The following is a description of a gene set: Up-regulated genes in the subpopulation of invasive PyMT cells (breast cancer) compared to the general population of PyMT cells. from publication Wang W, Wyckoff JB, Goswami S, Wang Y, Sidani M, Segall JE, Condeelis JS (PMID 17440055) Correlating tumor cell behavior in vivo with patterns of gene expression has led to new insights into the microenvironment of tumor cells in the primary tumor. Until now, these studies have been done with cell line-derived tumors. In the current study, we have analyzed, in polyoma middle T oncogene (PyMT)-derived mammary tumors, tumor cell behavior and gene expression patterns of the invasive subpopulation of tumor cells by multiphoton-based intravital imaging and microarray-based expression profiling, respectively. Our results indicate that the patterns of cell behavior that contribute to invasion and metastasis in the PyMT tumor are similar to those seen previously in rat MTLn3 cell line-derived mammary tumors. The invasive tumor cells collected from PyMT mouse mammary tumors, like their counterparts from rat xenograft mammary tumors, are a population that is relatively nondividing and nonapoptotic but chemotherapy resistant and chemotactic. Changes in the expression of genes that occur uniquely in the invasive subpopulation of tumor cells in the PyMT mammary tumors that fall on the Arp2/3 complex, capping protein and cofilin pathways show a pattern like that seen previously in invasive tumor cells from the MTLn3 cell line-derived tumors. These changes predict an enhanced activity of the cofilin pathway, and this was confirmed in isolated invasive PyMT tumor cells. We conclude that changes in gene expression and their related changes in cell behavior, which were identified in the invasive tumor cells of cell line-derived tumors, are conserved in the invasive tumor cells of PyMT-derived mouse mammary tumors, although these tumor types have different genetic origins. Mouse Gene Set: WANG_TUMOR_INVASIVENESS_UP studied in species Mus musculus, and this is the list of marker genes: Plod1, Brd4, Nelfe, Kifap3, Cd63, Ifitm1 (NCBI Gene Id 68713, interferon induced transmembrane protein 1), Aph1a, Wdr75 (NCBI Gene Id 96871), Ezr, Tjp2 (tight junction protein 2), Ppan, Mtmr3, Pou2f3, Psma2, Acat2, Sgpl1, Tex10, Fau, Pmpca, Sap18, Prkar1a, Stk11, Ezh2, Vdac3, Trim28, Nap1l1, Npc2, Rbm10, Cdca3, Per1, Psmb4, Ndufc2, Nucks1, Abcf1, Dpp3, Ndufs4, Klhl17, Ergic3, Hnrnpa2b1, Ap3m1, Syk, Ak2, Plac8, Ndufs6, Eif4g2, Tubb2b, Rps14, Cend1, Txndc9, Arih1, Tmsb10, Brd2, Rps20, Ctcf, Ap1g2, Pex13, Nfe2l2, Pnn, Commd3 (COMM domain containing 3), Ube2q1, Actg1, Slc34a1, Slk (STE20-like kinase), Rps7, Ifitm2, Psmg1, Eif4b, Krt4, Arpc3, Mapre2, Egln1, Ssb, Gtf3a, Aar2, Ipo5, Nhp2, S100a6, Gnas, Mov10, Paf1, Ehd1, Ormdl3, Ddx1, Ipo7, Lamb1, Agt, Hspe1, Rnaseh2a, Ccn1, Rbx1, Gfi1b, Amd1, Septin7, Kpna1, Abce1, Rps15a, Ppia, Fasl, Cdc42, Rpl7, Rpl30, Ncl, Gm8203, Nkapd1, Dgcr6, Faf1, Nefm, Cox8a, Hnrnpr, Hspa4, Lamc1, Nudcd2, Uba2, Nr3c1, Klf9, H2az1, Hsp90b1, Zc3h13, Nutf2, Rps3, Eif4g1, Ccdc47, Ubxn1, Btrc, Snrpd2, Rpl28, Nfkbia (NCBI Gene Id 18035), Postn, Eid1, Ifitm3, Bloc1s1, Krt19, Eno1, Cox7a2, Rfc1, Psph, Sub1, Pttg1, Tacc3 (transforming, acidic coiled-coil containing protein 3), Hnrnpu, Antxr2, Rpl32, Hint1, Higd1a, Creld2, Fkbp4, Plcd1, Gm15455, Ralbp1, Wwp2, Rpn1, Glul, Rpl19, Lrig1, Pnp, Atp5me, Supt5, Gabbr1 (NCBI Gene Id 54393), Ctdp1 (CTD phosphatase subunit 1), Hs6st1, Il7r, Ctsz, Ncs1, Fzd8, Rpl27, Serbp1, Rps29, Slc12a4, Marcks, Clec10a, Kpna2, Pabpc1, Tnrc6a, Ash2l, Usp47, Ssr3, Strap, Rpl8, Stip1, Rps6, Scaf8, Rpl14, Atp5pb, Abhd8, Add2, Raly, Bex3, Rplp2, 2700099C18Rik, Pcna, Rpl34, Usp14, Pxk, Eny2, Rpl21, Nf2, Srsf3, Fn1, Fnbp4, Rpl13a, Shroom3, Pip4k2a, Hspa5, Tardbp, Bag1, Naca, Cnn2 (calponin 2), Kpnb1, Col1a2, Kif11, Hebp1, Taf3, Zfp607a, Espn, Cirbp, Rras2, Prdx5 (peroxiredoxin 5), Hsph1, Paqr7, Abcf3 (ATP-binding cassette, sub-family F member 3), Ddx5, Tpr, Psmd3, Tubb4b, Rnf10, Hif1a, Agps, Sdha, Trir (telomerase RNA component interacting RNase), Ywhag, Lrrc17, Eif3b, S100a14, Cald1, Cycs, Pkm, Pcx, Fkbp9, Tkt, Tomm20, Nudt5, Clk2, Cox4i1 (NCBI Gene Id 12857), Snora33, Wdr3, Psma7, Dab2, Zmat1, Ubfd1, Spout1, Nedd8, Gm15772, Cd79a, Atp5pd (NCBI Gene Id 71679), AU040972, Mkrn1, Arpc5, Rps21, Hmgb2, Dazap1, Cks1b, Hsd17b4, B4galt5, Gfus, Aimp1, C1qb, Loxl3 (NCBI Gene Id 16950), Polr1d, Ralgds, Eif5b, Hdlbp, Ccnd1 (NCBI Gene Id 12443), Slc32a1 (NCBI Gene Id 97037), Ndufs2, Ybx1, Gm5177, Ipo9, Pcbp1, Gapdh, Rpa2 (NCBI Gene Id 99984, replication protein A2), Sptbn1, Ssna1, Cenpk, Glipr2, Smc1a, Hnrnpab, Wdr89, Vdac2, Polr1c, Vim, Cdhr4, Ssh1, Hmgcs1, Ndufb8, Psma4, Map1lc3b, Vcl, Mt1, Smg1, Atp2a1, Hspa8, Atp5f1a, Stat5a, Psmc5, Rps16, Gpn3, Eif3h, Pak1, Dpy30, Rplp0, Mrpl57, Rps8, Clec4a2, Brd7, Samd4b, Tpm1, Crabp2, Rpl27a, Stx7, Map3k12, Srsf7, Fasn, Pigf, Kcmf1, Elavl1 (ELAV like RNA binding protein 1), Atp6v1c1, Cpsf2, H3f3b, Npm1, Kif20a, Szrd1, Ankfy1, Mdp1, Ier2, Clta, Hspd1, Ncor1, Pros1, Arhgef12, Anxa7, Dbi, Camk2g (calcium/calmodulin-dependent protein kinase II gamma), Sec62, Pcm1, Cox7c, Evl, Rasa3, Arpp19, Akr1a1, Brd3, Smc5, U2af2, Fkbp3, Rps11, Rdx, Tes, Anxa2, Tgfbi, Cct5, Tubb5, Rps5, Cct2, Sec61b, Glud1, Mpdu1, Psmc2, Pik3cd, Rab7, Ski, Dedd, Eif2s2, Tubb6, Eif2b3, Acadl, Dio1, Adh5, Ptp4a2, Rpl35, Stat1, Rpl6, Cmtm5, Cct3, Gnao1 (guanine nucleotide binding protein, alpha O), Tuba1b, Eif4h, Atp1a1, Rpl18a, Ndufb7, Ube2k, Abcd3